The following is a description of a gene set: An inflammatory response driven by antigen recognition by antibodies bound to Fc receptors on mast cells or basophils, occurring within minutes after exposure of a sensitized individual to the antigen, and leading to the release of a variety of inflammatory mediators such as histamines. Human Gene Set: GOBP_TYPE_I_HYPERSENSITIVITY species: Homo sapiens, and this is the list of marker genes: FCGR2B, FCER1G, FCER1A, IGHE, BTK